The following is a description of a gene set: Genes up-regulated in wildtype bone marrow-derived macrophages treated with rosiglitazone: control versus IL4. from publication Szanto A, Balint BL, Nagy ZS, Barta E, Dezso B, Pap A, Szeles L, Poliska S, Oros M, Evans RM, Barak Y, Schwabe J, Nagy L (PMID 21093321) studied in species Homo sapiens C57Bl/6 wild-type and STAT6 KO mice were used to study PPARg and IL-4 signaling. Bone marrow of 3 mice per group was isolated and differentiated to macrophages with M-CSF (20 ng/ml). 20 ng/ml IL-4 was used to induce alternative macrophage activation and 1 uM Rosiglitazone (RSG) was used to activate PPARg. From each mouse 4 samples were generated: 1. M-CSF, 2. M-CSF+RSG, 3. IL-4 and 4. IL-4+RSG. All compounds were added throughout the whole differentiation process, and frech media was added every other day. Control cells were treated with vehicle (DMSO:ethanol). After 10 days, RNA was isolated and gene expression profiles were analyzed using Mouse Genome 430 2.0 microarrays from Affymetrix. Human Gene Set: GSE25088_ROSIGLITAZONE_VS_IL4_AND_ROSIGLITAZONE_STIM_MACROPHAGE_DAY10_UP, and this is the list of marker genes: CHFR (NCBI Gene Id 56732), CDS1, MED31, GSTM5, MAP4K2, CLPB, TRIOBP, LDHB, HSPA4L, ALG5, KLHL42, ULK2, MANF, SYS1, CYFIP2, KLHL20, INPP5F, TXNL4B, TMEM242, FHIP2A, FHIP2B, PON2, NR2C2AP, TRIM44, RTN4RL1, BORCS8, SMS, GANAB, SPIN1, GRN, TMX4, STXBP5, NCF1, LRP8, QPCTL (glutaminyl-peptide cyclotransferase like), ATP13A2, GGACT, DMAC2, SMIM15, CARMIL1, FKRP, AGTRAP, PENK, NFKBID, PAG1, RSPO2, LAMTOR4, MANBA, RNF14, TMED9, TMED8, ZNF335, TRPT1, KIAA0319L, TP53INP1, DCTN6, TRIM23, STRADB, YBX3, MTCL2 (NCBI Gene Id 90072), LGR5, ERBIN, TMEM60, FKBP2, DCAF17, KRT31, LRP12, HSD17B6, PRKDC, RNF181, ROCK1, SLC9A9, GALNT12, HBS1L, SERINC3, RAI1, SLC39A7, PTGR2, RGP1, DUSP7, METTL8, YIPF5, SERAC1, BLVRB, CTSW, HOXA7, NAPA, UGGT1, PIGH (phosphatidylinositol glycan anchor biosynthesis class H), EIF3D, RPL10, PABIR1, CLEC4G, IPO9, ZNF251, SEC22B, C11orf71, MBD5, FASTKD1, PGPEP1, C12orf75, DPY19L3, CBR1, RAPGEF1, C6orf62, DTX4, RHOBTB2, TOP1MT, BCL2L2, HIF1A, P2RY13, FAM120AOS, UBA5, PEX5 (NCBI Gene Id 5830), ZNF608, CDKN2D, SOCS7, CLBA1, TMEM63A, RCOR3, PRRX2, RNPEPL1, ANKRD40, TMF1, MED17, OSBPL7 (oxysterol binding protein like 7), TMEM86A, ITGAL, IGFBP3, GABARAPL1, PPP6R3, PIK3IP1, FOXO3, NLN, ASPH, PTPRS, RNASE4, PKNOX1, ATRAID, HMGN3, SCAP, WRN, RIPOR1, KCNU1, FAM210B, CEP104, GOLGA5, TMEM181, PDCD4, BCR, ZNF18, ITPR3, GALNS, ST8SIA4, MTMR1, HM13, LDLRAD3, RILPL1, MTPN, SREBF1, UPP2, RAD52, B3GNT2, CYB561A3, DFFB, VAV2, CCDC126, PHGDH, BET1, MR1, NFRKB, TACSTD2, BRD7, FKTN, MEN1, NCEH1, PRKAG2, ZCCHC24, PHRF1, COX8A, C12orf57, PHTF1, TRAPPC10, SPO11, SIAE, ADGRG3, GPN3, C2CD5, LMF1, KIF9, SEC63, PLS3 (plastin 3), CAMSAP3, TBCE, SEC62, GPR25, AK3, CHD2, THY1